Given this list of marker genes FBXO32, PDCD4, TAF4B, CCDC112, CCDC28A, YBX3, IER5, NEURL1B, RAP2B, STK4, DBIL5P2, TLR2, PIK3CG, MAPK14, ZBTB44, CRLF3, OIP5-AS1, PRPH, CAVIN2, NEK2, MS4A7, CXCR4, SDCCAG8, DAAM1, NR1D2, LONRF1, RERE, TSNAX, PSIP1, PRKCQ-AS1, ANAPC13, KLHL21, FOXO4, CRYBG1, KIF21B, LRATD2, MDFIC, LPAL2, HES1, ELMO2, NOLC1, GAS2L1, SATB1, GAS8-AS1, UPF2, DNMT3B, FBXO25, WIPI1, MBNL2, TANC1, LGALSL, FAM8A1, RAB27B, JMY, LRRC10B, PTPRE, ZBTB42, CTNNB1, MYCN, TMED8, NIPAL3, FRAT2, ALOX12P2, BMP2K, TWNK, FRAT1, NLK, SLC20A1, PHLPP2, JAKMIP2, CREBRF, RAPGEF2, RHOQ, PCMTD1, MNT, TNIP3, LINC00221, IRAG2, CENPU, RAD1 (RAD1 checkpoint DNA exonuclease), EEIG2, SEPHS1, RHEBL1, PNPLA8, AMMECR1, ATOSA, JADE2, VMA21, LRRC8B, AKAP5, PICALM, FBXL20, MYB, YPEL2, RIPOR2, NSD2, CHST2, CNTLN, IGSF3, TAL1, TBC1D15, SLC7A9, QRICH1, HERC1, NPAT, HSPA1A, ENHO, SLC38A2 (solute carrier family 38 member 2), C2orf88, GAB3, LINC01148, FAM117A, FHIP2A, RAB32, CARD8, COL4A2, G2E3, SYF2, CEBPD, NCAPD3, CCNA2, POM121L8P, TAGAP, SCHIP1, BTG1, WDR26, PPM1K, SPRY1, ENSG00000253614, GJA8, VRK1, STAM, POLR1F, AHCTF1, RNF44, NUP98, SLCO4C1, BCL2, ZNF367, FOSL2, AUH, GFI1B, RAB27A, TP53INP1, CIR1, LINC00421, RFX5, FZD4, ST8SIA4, SLC25A36, CASP3, MAPRE2, LCP2, P2RY8, MEIS1, RASSF5, FAM217B, GRB10, ADAMTS3, CNNM3, FDFT1, TIMM23, MYCT1, LARP4, IRS2, FOXK1, AFF1, DCBLD2, HEXIM1, RMI2, NRROS, TFEC, TSEN2, YPEL5, NDC80, RABEPK, TNRC6B, ERG, LCOR, ZNF30, FAM117B, BCCIP, ACVR2B, BCL11A, ZMYND8, SPHKAP, HBP1, TMT1A (NCBI Gene Id 25840), SOX6, IFNGR1, IDI1, CCZ1B, STON2, HECA, C11orf21, DUSP6, ST3GAL2, BRD10, here is a description of the gene set: from publication Dudziak D, Kamphorst AO, Heidkamp GF, Buchholz VR, Trumpfheller C, Yamazaki S, Cheong C, Liu K, Lee HW, Park CG, Steinman RM, Nussenzweig MC (PMID 17204652) studied in species Homo sapiens Dendritic cells (DCs) process and present self and foreign antigens to induce tolerance or immunity. In vitro models suggest that induction of immunity is controlled by regulating the presentation of antigen, but little is known about how DCs control antigen presentation in vivo. To examine antigen processing and presentation in vivo we specifically targeted antigens to the two major subsets of DCs using chimeric monoclonal antibodies. Unlike CD8+ DCs that express the cell surface protein CD205, CD8- DCs, which are positive for the 33D1 antigen, are specialized for presentation on MHC class II. This difference in antigen processing is intrinsic to the DC subsets and associated with increased expression of proteins associated with MHC processing. Human Gene Set: GSE6259_BCELL_VS_CD8_TCELL_DN Genes down-regulated in B lymphocytes versus CD8 T cells.